The following is a description of a gene set: studied in species Homo sapiens The cleavage of DNA during apoptosis, which usually occurs in two stages: cleavage into fragments of about 50 kbp followed by cleavage between nucleosomes to yield 200 bp fragments. Human Gene Set: GOBP_APOPTOTIC_DNA_FRAGMENTATION, and this is the list of marker genes: DICER1, ENDOG, EXOG, BAX, APAF1, NMNAT1, DNASE1L3, GATA5, IL6 (NCBI Gene Id 3569), DFFA (NCBI Gene Id 1676), DNASE2, HSF1, FOXL2, CECR2, VPS54, CIDEA, DFFB, DNASE2B